Given this list of marker genes IRAK1, MYD88, NLRP12, IRAK4, PELI1, IRAK3, APP, PALM3, IRAK2, TRAF3, PELI3, PELI2, SIGIRR, here is a description of the gene set: studied in species Homo sapiens The series of molecular signals initiated by an extracellular ligand binding to the receptor Toll on the surface of a target cell, and ending with the regulation of a downstream cellular process, e.g. transcription. Human Gene Set: GOBP_TOLL_SIGNALING_PATHWAY